Given this list of marker genes PTGS2, PTGER2, GNAQ, PTGES, GNAI1, LTA4H, RB1, PTGS1 (prostaglandin-endoperoxide synthase 1), PTGER3, NRAS, TBXAS1, PTGER1, LTC4S (leukotriene C4 synthase), GNAS, CYSLTR1, PTGIS, IGFBP5, PTGER4, SIRT1, PLA2G4A, ALOX15B, PLCB1, ALOX5AP, HRAS, MAPK11, KRAS, ADCY3, ALOX15, PTGDS, ALOX5, CDKN1A, TP53, PRXL2B, ALOX12, here is a description of the gene set: Human Gene Set: WP_PROSTAGLANDIN_AND_LEUKOTRIENE_METABOLISM_IN_SENESCENCE species: Homo sapiens Prostaglandin and leukotriene metabolism in senescence